Given this list of marker genes CALM1, CAMKK2, CREB1, CAMK4, CAMK2G, CAMK2B, KPNA2, CAMKK1, here is a description of the gene set: species: Homo sapiens Human Gene Set: REACTOME_CREB1_PHOSPHORYLATION_THROUGH_THE_ACTIVATION_OF_CAMKII_CAMKK_CAMKIV_CASCASDE CREB1 phosphorylation through the activation of CaMKII/CaMKK/CaMKIV cascasde